Given this list of marker genes Fcf1, Rpp40, Rcl1, Abt1, Kri1, Rrs1, Nop9, Rps21, here is a description of the gene set: Endonucleolytic cleavage between the SSU-rRNA and the 5.8S rRNA of an rRNA molecule originally produced as a tricistronic rRNA transcript that contained the Small SubUnit (SSU) rRNA, the 5.8S rRNA, and the Large SubUnit (LSU) rRNA, in that order, from 5' to 3' along the primary transcript. Mouse Gene Set: GOBP_ENDONUCLEOLYTIC_CLEAVAGE_IN_ITS1_TO_SEPARATE_SSU_RRNA_FROM_5_8S_RRNA_AND_LSU_RRNA_FROM_TRICISTRONIC_RRNA_TRANSCRIPT_SSU_RRNA_5_8S_RRNA_LSU_RRNA studied in species Mus musculus